The following is a description of a gene set: Mouse Gene Set: REACTOME_POSITIVE_EPIGENETIC_REGULATION_OF_RRNA_EXPRESSION species: Mus musculus Positive epigenetic regulation of rRNA expression, and this is the list of marker genes: Kat2a, Myo1c (myosin IC), Taf1d, Taf1c, Gsk3b, Baz1b, Polr2l, Tbp, Sf3b1, Polr1h, Taf1b, Polr1g, Polr1e, Ercc6, Ddx21, Ep300, Polr2f (NCBI Gene Id 69833), Dek, Polr1b (NCBI Gene Id 320298), Smarca5, Polr1f, Polr2e, Mybbp1a, Actb, Polr1a (polymerase (RNA) I polypeptide A), Polr1c, Taf1a, Kat2b, Polr2k, Polr2h